The following is a description of a gene set: Human Gene Set: GSE17974_CTRL_VS_ACT_IL4_AND_ANTI_IL12_72H_CD4_TCELL_DN Genes down-regulated in comparison of untreated CD4 T cells at 0 h versus the cells treated with IL4 and anti-IL12 at 72 h. studied in species Homo sapiens The aim of this dataset was to study in detail the transcription kinetics initiated by cytokine IL-4 in early differentiation of Th2 cells. from publication Elo LL, Järvenpää H, Tuomela S, Raghav S, Ahlfors H, Laurila K, Gupta B, Lund RJ, Tahvanainen J, Hawkins RD, Oresic M, Lähdesmäki H, Rasool O, Rao KV, Aittokallio T, Lahesmaa R (PMID 20620947), and this is the list of marker genes: NUDCD1 (NCBI Gene Id 84955), HNRNPC, STN1, KEAP1, IARS2, GDI2, ATP6V1F, ANKZF1, PLCXD1, ATG7, QPRT, ASCC1 (NCBI Gene Id 51008), VPS26C, CYB5B, LSM2, GPANK1, NEMP1, FNTB, HOMER2, POLD3, LMAN2, IDI1, FAM83D, CAPG, IGSF8, CEP19, STXBP1, SLC39A8, HDHD5, ANXA4, HNRNPA2B1, GCK, HIRIP3 (NCBI Gene Id 8479), ZNF232, FGGY, SYT11 (synaptotagmin 11), GOT2, CDK2, GEMIN6, GNGT2, ST8SIA4, CEP152, RUVBL2, DNAJB6, SND1, TRIB3, BRIP1, LRRC32, HOMER1, JPH1, RUSC1, AGPAT2, GRHPR, EHHADH, FAM98B, NCR3, SH2D3C, DARS1, MRPL18, FAM98A, CD109, ISCA2, MRPS28, SLC25A43, YARS2, ACOX3, TPP1, SLC37A3, ZNF146 (NCBI Gene Id 7705), FHOD1, C1orf21, SBF2-AS1, NOL3, MMP12, HADHB (NCBI Gene Id 3032), BCAP31, DBI, GLE1, SGCB, GMDS, RAD51C, ZNF826P, CAP1, CTNNAL1, USP28, HMGB3, NIF3L1, LMNB1, ACAT1, PSMG1, TXNRD1, MGAT1, TNFRSF4, OXSR1 (NCBI Gene Id 9943), NENF, ATP23, RAD51D (NCBI Gene Id 5892), CAMK1, FAM89A, MTHFD1, NRM, NCAPD3, IMMT, JAKMIP2, ACADVL, DCP1B (decapping mRNA 1B), NFE2L3, CLIC4, PPIL1, INTS2 (NCBI Gene Id 86656), ASTN2, TK1, PSMB2, SHMT1, ETHE1, FUCA2, PTPN22, SLC29A1, PRDX1, ELP5, EXO1, JAML, MPG, CD82, NUP42, DHPS, CPNE2, THYN1, BDH1, C12orf75, RTL8C, MAP3K6, SERPINH1, TMEM273, RCC1, EZH2, DIAPH3, CEP128, BCAT1, MEOX1, CMSS1, DPAGT1, NSD2, HPDL, RHEBL1, DLG5, TMEM165, TCEA1, INTS13, TWF2, LINC01128, SMIM7, DHRS1, CENPF, PIGM, FUT11, RAP1A, ERG28, GBP2, P4HA1, HLTF, TMEM120A, PAM, SNX12, YWHAE, CNOT1, MFSD4B, PHLDA1, ITM2C, MTNAP1, AARS1, ASPHD2, KLHL17, CLYBL, NFXL1, GRK3, C4orf3, RAB27A, RNGTT, TEX30, CLDN1, C1GALT1C1, IGF2BP3 (NCBI Gene Id 10643), GPNMB, MTA3, MEAK7, MAP3K21, CDC25A, MTCH2, S100A10, NCKAP1L, RECQL4, ZNF410, PRIM1, BCAT2, HADHA, PDAP1